Given this list of marker genes RUNX1, PRDM16, ZBTB46, TRIB1, INPP5D, CUL4A, RARA, CEACAM1, ADIPOQ, C1QC, here is a description of the gene set: species: Homo sapiens Any process that stops, prevents, or reduces the frequency, rate or extent of granulocyte differentiation. Human Gene Set: GOBP_NEGATIVE_REGULATION_OF_GRANULOCYTE_DIFFERENTIATION